Given this list of marker genes TGFB1, TGFBR2, TGFBR1, here is a description of the gene set: species: Homo sapiens Reactome Pathway: Loss of Function of TGFBR2 in Cancer Loss-of-function of transforming growth factor-beta receptor II (TGFBR2) is most prevalent in colorectal cancer. Over 60% of colorectal cancers with microsatellite instability (MSI) harbor inactivating mutations in both alleles of TGFBR2, mostly 1 or 2 bp deletions in the 10 bp adenine repeat that codes for three lysine residues in the extracellular domain of TGFBR2. These small deletions result in a frameshift and a premature stop codon. TGFBR2 kinase domain (KD) mutations are found in ~20% of microsatellite stable (MSS) colorectal cancers and these are mostly missense mutations that results in substitution of conserved amino acids in the kinase domain, likely impairing the catalytic activity of TGFBR2 KD mutants. The silencing of TGFBR2 gene via promoter methylation has been reported in B-cell lymphoma. Knockout of murine Tgfbr2 in colonic epithelium promotes azoxymethane-induced colon cancer formation and increases the number of adenomas and adenocarcinomas in Apc+/- mice. part of: Signaling by TGF-beta Receptor Complex in Cancer